Given this list of marker genes Chka, Actg1, Plscr1, Sema3b, S100a11, Nsdhl, Alcam, Trp53inp1, Clu, Srebf2, Dhcr7, Nfil3, Lgals3, Hmgcs1, Pdk3, Stard4, Acss2, Plaur, Atf3, Jag1, Adh4, Fads2 (NCBI Gene Id 72957), Ech1, Fabp5, Idi1, Mal2, Hmgcr, Fbxo6, Acat2, Aldoc, Sqle, Pcyt2, Mvk, Pmvk, Lgmn (legumain), Tm7sf2, Ebp, Fasn, Lss, Stx5a, Antxr2, Ldlr, Fdft1, Lpl, Pparg, Errfi1, Abca2, Fdps, Gstm7, Tmem97, Avpr1a, Ctnnb1, Gldc (glycine decarboxylase), Gpx8, Anxa5, Cxcl16, Mvd, Niban1, Cpeb2, Gusb, Hsd17b7, Trib3, Cyp51, Pnrc1, Tnfrsf12a, Ethe1 (NCBI Gene Id 66071), Sc5d, Atxn2, Atf5, Gnai1, Cd9, here is a description of the gene set: from publication Howe DG, Blake JA, Bradford YM, Bult CJ, Calvi BR, Engel SR, Kadin JA, Kaufman TC, Kishore R, Laulederkind SJF, Lewis SE, Moxon SAT, Richardson JE, Smith C (PMID 30224793) Mouse Gene Set: HALLMARK_CHOLESTEROL_HOMEOSTASIS species: Mus musculus Mouse genes annotated to HALLMARK_CHOLESTEROL_HOMEOSTASIS based on orthology mappings provided by the Alliance Genome Consortium